The following is a description of a gene set: EZH2 is a Polycomb group (PcG) protein that promotes the late-stage development of cancer by silencing a specific set of genes, at least in part through trimethylation of associated histone H3 on Lys 27 (H3K27). Nuclear inhibitor of protein phosphatase-1 (NIPP1) is a ubiquitously expressed transcriptional repressor that has binding sites for the EZH2 interactor EED. Here, we examine the contribution of NIPP1 to EZH2-mediated gene silencing. Studies on NIPP1-deficient cells disclose a widespread and essential role of NIPP1 in the trimethylation of H3K27 by EZH2, not only in the onset of this trimethylation during embryonic development, but also in the maintenance of this repressive mark in proliferating cells. Consistent with this notion, EZH2 and NIPP1 silence a common set of genes, as revealed by gene-expression profiling, and NIPP1 is associated with established Polycomb target genes and with genomic regions that are enriched in Polycomb targets. Furthermore, most NIPP1 target genes are trimethylated on H3K27 and the knockdown of either NIPP1 or EZH2 is often associated with a loss of this modification. Our data reveal that NIPP1 is required for the global trimethylation of H3K27 and is implicated in gene silencing by EZH2. Genes down-regulated in PC3 cells (prostate cancer) after knockdown of NIPP1 by RNAi. Human Gene Set: NUYTTEN_NIPP1_TARGETS_DN from publication Nuytten M, Beke L, Van Eynde A, Ceulemans H, Beullens M, Van Hummelen P, Fuks F, Bollen M (PMID 17724462) studied in species Homo sapiens, and this is the list of marker genes: SEC16A (NCBI Gene Id 9919), TYMS, RBM3, DCP1A, SLC2A4RG, LAMA5, ACSL3 (NCBI Gene Id 55484), ARHGEF16, SHROOM2 (NCBI Gene Id 357), SERPINH1, DSTN, NACC1, OSBPL3, UBE2Q2, PCMTD1, NUDT8, HMGN4, WFIKKN1, AIF1L, NSD2, CDK2AP2, CUL5, AJUBA, NNT, FITM2, ITPKA, MUC5AC, TXNIP (NCBI Gene Id 10628), MAGT1, FAM89A, UCP2, LTBR, SLC36A4, PLCL2, SERBP1, WSB2, ROR1, S100A10, CMTM4, H2AZ2 (H2A.Z variant histone 2), TTYH3, PHAX, TULP4, TRIM29, ZNF106, IMPA1, TOMM20, LBR, SPDEF, TMEM45B, GOLGA2, NRBF2 (NCBI Gene Id 91155), OSBP2, MID1IP1, SFXN1, GK, HMGA2, SDC1, SEL1L, MACROH2A1, PDCD10, FAM131B, MYL6, SMU1, CWF19L1, DNAJA1, COCH, LEPROT (leptin receptor overlapping transcript), CAMK2N1, CDK7, EPB41L4B, FAM89B, ACTG1, TNS4, HOXA13, SLC16A1, CCDC86, TCF19, UBE2M, SLC20A1, MCAM, SIKE1, SLC16A14, USF3, PRKAR1A, KPNB1, TACC1, TMPRSS2 (transmembrane serine protease 2), ESAM, PRPS1, ARL1, CRIPT, NF2, TMEM59, LIMD2, RBP4 (NCBI Gene Id 5950), CBR3, LYRM7, PUM2, ANO6, ZCCHC14, MDK, MAP3K14 (mitogen-activated protein kinase kinase kinase 14), RAD51C, PABPC3 (NCBI Gene Id 91297), ENTPD3, VPS26A, GLI3, SNX10, CERS6, TPD52L2, SPTSSB, FOXN3, ELOC, KEAP1, TRIM8, IQCK, AFG3L1P, ATG13, RALGAPA2, RPS6KA5, CCNY, PPP1CB, PREX1, DAG1, MND1, CKB, INAVA, IL6R, UBE2G2, MARCHF5, TTC9C, CTHRC1, BAG5, LRRC8A, MKNK2, NECAP2, SLC48A1, BORCS7, SURF4, NPTX1, GALNT3, GID8, TCF7L2, OTULINL, TCF3, PRMT2, ERGIC2 (ERGIC and golgi 2), BRWD1, HTT, NANOS1, PRPS1L1, KIAA2013, FIBP, PTN, PNPLA2, ACOX1, RALBP1, RAB3D, TMEM106C, LZIC, HPSE, GPR68, HOXB13, CAST, CDH11, ADAT1, CEACAM6, VASN, TMED7, PLXND1, KIF4A, IQSEC1, EXPH5, ISYNA1, RBM12, FUCA2, H2AX, CCDC91, TRPC4AP, SLC35E1, CEMIP, TLE5, PLP2, PRRT3, NIBAN1, NGEF, TMTC1, HDGF, ARF4, KRT18P55, BTG3, DEPDC1B, FAM220A, RYBP, PHLDA1, ORMDL2, EIF4G2, AP3M1, UBE2D4, SLC37A2, TPRG1L, ACER3, PDZD8, GTDC1, SLC12A6, LAMC1, ZNF639, C5orf15, POLA1, ATP11B, ESYT2, BMPR2, KLF5, GPRC5A, MAPK13, NAA15, ZNF518B, CCNJL, TTC38, DIMT1, MIRLET7BHG, ZNF71, DYNC2I2, KTN1, SSB, KCNK1, SERINC1, NT5DC2, GALNT10, EPN3, HS3ST5, SKI, NFYB, ACAA1, RGS10, TMEM184A, TAPT1, E2F8, TMEM184B, CILK1, NIPAL3, MBOAT2, BMP2K, TUBB6, SLC44A1, PCSK9, KCNN4, ARHGAP42, ALDH5A1, NMT2, PDXK, UGDH, MYO1C, KCTD5, LOXL4 (NCBI Gene Id 84171), DICER1, SMC1A, RNF141, NDFIP2, PKD2, TENT5C, PHLDA3, LMBR1, KIAA1958, TMTC4, CYP1B1, DIPK2A, WDR76, RAP2C, UBR7, UBE2N, FBXO5, TMEM154, CDK6 (cyclin dependent kinase 6), PATZ1, ANXA3, ERC1 (ELKS/RAB6-interacting/CAST family member 1), GPR107, B4GALT6, CUX1, PRPS2, MAP4K4, AMFR, LMNB1, KCTD20, B4GALT1, KCNJ2, ZBED1, ACTB, ADGRF1, GNAI1, HIPK1, ZNF702P, SLC16A4, LSR, LIMCH1, SSX2IP, GALNT4, EHF, LYPLA1, AAGAB, STING1, PRPSAP1, SPRY4, CNEP1R1, SNTB2, ADAM9, SLFN11, CHRM2, INHBB, VMA21, PIR (NCBI Gene Id 8544), SIX4, REEP4, SLC25A24, NUP210, EEPD1, SLC35F5 (solute carrier family 35 member F5), NUCKS1 (NCBI Gene Id 64710), RANBP9, CTSZ, LRATD1 (NCBI Gene Id 654112), PARD6G, TMEM92, HOXA10, SVIP, SLF1, NMNAT2, LYSMD3, ALDH1A3, RAP2A, LCN2, TAB3, SLC35D2, RAD23B, CLINT1, AURKA, PEX19, AKT1S1, MALL, TPRKB, AGMAT, RBM18 (NCBI Gene Id 92400), DLC1, ATPAF1, JMJD4, TGFB2, RPS6KA4, YWHAG, PYGB, TMED4, KLHL5, DPYSL2, RRP1B, YME1L1, ARID1A, TRERF1, PBXIP1 (NCBI Gene Id 57326), TRIM33 (NCBI Gene Id 80027), CWC27, ZNRF1, ARSJ, WDR37, PJA2, PACSIN2, TBL1XR1 (NCBI Gene Id 81612), PBX1, ERLIN1, EHBP1L1, NCEH1, TMCC1, KDELR2, F2R, FZD4, CCDC50, BRD4, FUBP1, TGOLN2, ANO1, GIPC1, PINK1, NUP160, TM7SF2, CAV1, TUBA4B, PFAS, SEPHS2, NUP50, CHRM3, SLAIN2, GPR161, ST3GAL1, SOX21, DOK7, DOCK11, COL2A1, INF2, TUBB1, SYNJ2BP, ORAI2, ABCA1, OSBPL2, SLMAP, MIR1915HG, PHF19, TMEM41B, ERO1A, HNRNPA0, SLC25A4, FAIM (NCBI Gene Id 55179), PDIK1L, SORBS3, PARP8, SAPCD2, CXXC5, TUBA4A, AAMP (NCBI Gene Id 14), DDR1 (NCBI Gene Id 780), GABPB2, SLC40A1, EMC9, TCEA3, PTGES, PTTG1IP, SLC35F6, SPRYD7, FER, CALB1, ASAP1 (ArfGAP with SH3 domain, ankyrin repeat and PH domain 1), IGF2BP2, FUT4, SLC43A3, ATP2C2, PAK1IP1, MCM6, OSGEP, CCND1, RPS6KB1, SMPD1, NOTCH1, ABHD3, ARHGAP28, MIS18A, KRT18, TUBB8, GOLGA1, ANTXR2, RAB4A, DUSP5, AASDHPPT, NUDT21, ADIRF, DENND2A, SMARCA2, ROBO1, TET1, GJB2, PCGF3, SDF4, EPHB3, P4HB, TBX2, CPSF6, IMPA2, PLA2G7, TSPAN5, OSBPL11, CASP9, ABHD13, SLC35B2, PDE4A, ANLN, UBE2W, PPP2R1B, RAB10, VASH2, NUDT16L2P, TBL1X, MED1, ECT2, RRP7BP, TUBB4B, SLPI, ULK1 (NCBI Gene Id 8408), USP37, GCH1, CUL3, SCRN1, NFATC3, AMMECR1 (AMMECR nuclear protein 1), RAB27A, CAV2, XIAP (X-linked inhibitor of apoptosis), PIDD1, PRR15, MALT1, TMEM203, PHTF1, RTN4, SRPRA, ZRANB1, SCPEP1 (NCBI Gene Id 59342), GGCX, SH3BGRL3, RIOK3, RCC2, ARNT, TFPI2, PAK2, SUSD3, MKI67, GPRC5B, RHOF, CEP97, IGFBP6, FBXO21, SCIN, ANAPC16, DCXR, SPAST, SH2B3, TMEM245, CHRNA5, KMT5A, NUDT15, PAQR8, NHERF1, PLCD3, ANPEP, RCN1, DBNDD2, ATP2A2 (NCBI Gene Id 488), MISP, CAPZA2, DDX39A, EPAS1, TFF1, ATP2A3 (NCBI Gene Id 489), MAGED1, VSTM2L, IGSF8 (NCBI Gene Id 93185), RAB18, BIK, KIF2A, ERLIN2, CDK2AP1, LPGAT1, FOXM1, ANP32E, ENTPD4, PPP6C, SP3, ELF3, HMGB2, CPT1A (NCBI Gene Id 1374), GPR157, RAI14, PPP2CB, FOXQ1, SGPP1, GALNT2, XPO4, TMEM97, ATP6V1G1, MCFD2, RNF13, B3GNT3, ANTXR1, ZNF302, ZNF503, RUNX1, PIP5K1A, PCDH18, RNF11, JUP, PHLDA2, TRMT5, EPCAM, NLRP3, RRM2, PABPC1, CXCL5, EXOSC2, HMGCR, QSOX1, SLC4A11, GINS3, KRR1, CDKN1C, ELAVL1, PCDH20, LPP, TMPO, ROCK2, TMEM121, AHNAK, VEGFA, DHCR24, MYO1D, MTMR9, TMCO3, SLC1A1, CCDC47, CMPK1 (NCBI Gene Id 51727), PAPOLA, GSKIP, ANP32A, NCOA1, PTBP1, SPINT2, SPTLC2, SLAIN1, GMCL2, C5, MXI1, STARD3NL, IL6ST, CLSPN, LRP10, PHC2, EIF5A, MAN2A1, CRTAP, NR2F2, ABCG1, NUDT4 (NCBI Gene Id 57236), TBL1Y, MAL, ARSK, PLCXD1, SEPTIN2, ENC1, SESN1, CRK, EHMT2, TTYH2, MAFF, PECAM1, GCAT, SETD7, RCAN3, GOLT1B, STEAP3, KLF11, UBALD2, PHACTR3, NEBL, TNFAIP8L1, GNB5, ADGRG6, KREMEN2, CARD9, CREBL2, RB1CC1, PARVA, SLC38A2, DPM3, ORC4, BTBD3, FAM111B, FOXA1, MTARC1, ZBTB2, SHB, NKAPD1, DHRS3, SLC9A6, TMEM126B, SGCB, MPDU1, POLR2L, S100P, ADORA2B, PLCE1, ATP6V1A, OCIAD1, CASP3, EEF1AKMT2, FAM120A, HMMR, KIAA0319L, N4BP2, FSCN1, SLC12A2, LAMP2, SEC14L1, VCL, SEC61A1, LRRC58, TFF2, FAF2, RDH10, JADE2, PRICKLE1, LHX2, MARCHF6, LARP4B, SEMA5A, C18orf54, KHK, NCOA6, FAM20A, GLUD1, GNAI2, EPHX1, SLC25A39, SS18L2, TDP2, EPHA2, ANKRD17, SMS, AGR2, GNAS, REEP3, PRR11, TGFB1, WDR72, DCP2, ADI1, NR1D2, GFM1, GRHL2, CDKN2C, ZBTB38, MAP3K2, IPO5, SEC23A, GRK6, WDR93, SYK, STK39, CEP41, FBXL3, MXD1, NMD3, CNTNAP3B, ARPP19, DHTKD1, SSPN, ELMOD2, DENR, CEACAM1, PRTFDC1, RAC2, SCARA5, CAPZA1, GBX2, TRIM2, LRRC14, YAF2, ATP13A3, VSIG10, ITGA3, XK, PRDX3, GTPBP6, ZNF473, KDSR, CDS1, ASPH, MED30, PPP1R8, ADGRG1 (NCBI Gene Id 9624, adhesion G protein-coupled receptor G1), GOLGA3, MAPK6, HPRT1, SEC62, MAK16, FFAR4, GCHFR, APH1A, SREK1IP1, MEX3D, ARL6IP6, KAZALD1, PURB, PSMD12, UHRF1, TSPYL1, CHPT1, FGFBP1, RNF138, HEXIM1, ZDHHC17, APIP, PLPP6, SLC16A9, SNAPC1, ETV4, TMED10, PYCARD, ZYX, RIF1, ZNF706, KIF20A, MBNL2, CYB5R1, TLCD3A, DCTPP1, SLC7A1, C3orf38 (NCBI Gene Id 285237), PDCL, IER5L, GNA11, ANKRD53, SYNE2, SDR16C5, LEPROTL1, ZMPSTE24, ATF5, FGFRL1, STK10, DDIAS, ACKR3, IL17RC, APOLD1, CMTM6, WNT4, ZNF326, KAT2B, TUBB4A (NCBI Gene Id 1864), KLF2, AP2B1, SPINT1, MFSD6, GALNT7, SCOC, NCBP1, ABCC3, CCNG2, THAP5, LRATD2, FNBP1 (NCBI Gene Id 23048), MAP2K4, HUWE1 (NCBI Gene Id 54789), ZNF367, HSD17B2, CLOCK, FAM114A1, NSF, PDGFB, PLEKHF2, SERINC2, CRIP1 (NCBI Gene Id 1396)